The following is a description of a gene set: Mouse Gene Set: REACTOME_NITRIC_OXIDE_STIMULATES_GUANYLATE_CYCLASE Nitric oxide stimulates guanylate cyclase studied in species Mus musculus, and this is the list of marker genes: Prkg1, Pde11a, Pde10a, Pde2a, Pde1a, Irag1, Nos1, Nos2, Nos3, Pde5a, Pde9a, Pde1b, Itpr1